The following is a description of a gene set: Human Gene Set: MIR224_3P Genes predicted to be targets of miRBase v22 microRNA hsa-miR-224-3p in miRDB v6.0 with MirTarget v4 prediction scores > 80 (high confidence targets). studied in species Homo sapiens from publication Chen Y, Wang X (PMID 31504780), and this is the list of marker genes: PROK2, ATF7IP, TUBGCP5, GARRE1, CDK6, SNX1, TLR8, SPICE1, FLRT3, WWTR1, SMAD2, METTL13, PRKAA1, FMR1, YWHAQ, PPFIA2, TXNDC9, ETV1, GAB2, DOCK7, AMMECR1L, HNRNPLL, RCAN3 (NCBI Gene Id 11123), MTCL3, TNRC6B, UBE2Q2, ENTPD4 (ectonucleoside triphosphate diphosphohydrolase 4), MYEF2, FAHD1, DHFR2, NHLRC1, TAF1C, BEND4, MBNL3, ABHD3, NDUFA5, KLHL8, VAPA, MST1L, TOR1AIP1, NSD2, ZNF594, SLC12A6, ZDHHC6, EIF2A, TMTC4, ATXN1L, SYNJ1, PTPN11, KIF7, BCL2, TP63, ARPC5, ADGRF2P, ZC3H8, UBR3, PRKG1, ABCD4, STAG1, PPM1E, COL5A2, FANCD2, TRPM7, PERP, AKAP6, CBLL1, RAB29, DCHS2, AMMECR1, GEM, ZMAT3, CASKIN1, ATP1B1, TBC1D9, NAP1L2, KPNA4, WT1, TAOK3, KLHL31, USP8, EEF1AKMT2, FBXO8, PHIP, P2RY10, SEMA5A, LARP1B, DIP2A, NPAT, CUL1, CSNK1A1, MID1, RASGRP3, CCSER2, LSM5, FHIP2A, RHD, PARP15, RSL24D1, GOLGA1 (NCBI Gene Id 2800), RAP2A, DPYSL2, TM2D1, WDFY3, RB1CC1, RAB14, MEF2C, DLG2, SLC45A2, ATXN7, ADA2, CLVS1, RPS3, ARHGAP5 (Rho GTPase activating protein 5), CNOT6L, WDTC1 (NCBI Gene Id 23038), CADM1, NFAT5, MRPL47 (mitochondrial ribosomal protein L47), TNFSF4, DHFR, RBM47, SMURF2, MAFB, NEUROD1, SNAP25, SCAF11, RAVER2, SPRY3, RAC1, MCMDC2, SC5D, PIK3CA, ARMC10, TCP11L2, CHIC1, DEPDC4, PLXDC2, NEXMIF, MZT1, ABCB5, SLCO4C1, ZNF704, TMEM266, ELAVL1, GIN1, NRG3, ARHGAP29, PLIN4, OAS1, RAPGEF6, TTF2, INO80D, FST, LZIC, HORMAD1, STK4, FEM1C, CSTF2T, C15orf40, RABEP1, DIMT1, SLC4A7, HS3ST3A1, RFX7, KRTAP3-1, ZBTB6, PDIA5, GDAP2 (NCBI Gene Id 54834), NFIB, RAB38, DNAJC25, CCDC186, ZC3H7A (NCBI Gene Id 54895), PIP4P2, LMO7, LPAR1, MTMR3, SIAH1, SHOC2, MPO, ZBTB20, NOXRED1, GPRASP3